Given this list of marker genes GPLD1, PLCE1, DAGLA, PLIN5, PLA2G15, DGAT1, FBXW7, MOGAT2, ACSL1, PNPLA3 (NCBI Gene Id 80339), MIR29B1, SCARB1, LPIN2, DGAT2L6, SIK1, MOGAT1 (monoacylglycerol O-acyltransferase 1), AWAT2, PLA2G4A, MIR30C1, MIR548P, LPIN1, PCK2, GK, AGMO, PCK1, NR1H3, THRSP (NCBI Gene Id 82916), SLC27A1, MFSD2A, TMEM68, AGPAT2, SIRT1, C3, NR1H2, GPAT4, CNEP1R1, LDLR, CTDNEP1, GPAM, AVIL (NCBI Gene Id 80056), MOGAT3, PNPLA2, SREBF1, GPAT3, TMX1, DAGLB, DGAT2, LPGAT1, GPAT2 (glycerol-3-phosphate acyltransferase 2, mitochondrial), LPIN3, KAT5, here is a description of the gene set: studied in species Homo sapiens Human Gene Set: GOBP_NEUTRAL_LIPID_BIOSYNTHETIC_PROCESS The chemical reactions and pathways resulting in the formation of neutral lipids, lipids only soluble in solvents of very low polarity.